The following is a description of a gene set: Mouse Gene Set: GOMF_URIDYLYLTRANSFERASE_ACTIVITY Catalysis of the transfer of an uridylyl group to an acceptor. species: Mus musculus, and this is the list of marker genes: Tut7, Uap1, Galt, Uap1l1, Tut4, Ugp2, Tut1 (NCBI Gene Id 70044)